The following is a description of a gene set: Human Gene Set: GOBP_MIRNA_CATABOLIC_PROCESS studied in species Homo sapiens The chemical reactions and pathways resulting in the breakdown of miRNA, microRNA, a class of single-stranded RNA molecules of about 21-23 nucleotides in length, which regulates gene expression., and this is the list of marker genes: DIS3L2, LIN28B, OIP5-AS1, SND1, DNM3OS, ZC3H12A, PNPT1, XIST, ELOB, ZSWIM8, TENT2, MALAT1, PARN, TENT4B, ELOC, TUT4, QKI, HOTTIP, LIN28A, NEAT1